The following is a description of a gene set: species: Homo sapiens Human Gene Set: chr5q34, and this is the list of marker genes: RNU6-164P, RNU6-168P, NUDCD2, LSM1P2, RPL21P59, MAT2B, GABRA1, RPL7P20, MIR218-2, LINC03000, LINC01938, GABRG2, RPL10P9, PANK3, MRPL57P6, ATP10B, TENM2, CCNG1, RN7SKP60, SLIT3-AS2, WWC1 (NCBI Gene Id 23286), LINC01202, LINC01947, HMMR, RARS1, LINC02159, TENM2-AS1, GABRB2, GABRA6-AS1, GLRXP3, ENSG00000253660, RPLP0P9, MIR103B1, SLC2A3P1, ARL2BPP5, FBLL1, LINC02143, RNU6-209P, MIR103A1, ENSG00000253469, HMMR-AS1, GABRA6